The following is a description of a gene set: species: Homo sapiens Any process that activates, maintains or increases the rate of muscle development. Human Gene Set: GOBP_POSITIVE_REGULATION_OF_MUSCLE_ORGAN_DEVELOPMENT, and this is the list of marker genes: ERBB3, MYOD1 (myogenic differentiation 1), MYF6, DLL1, PRKAA1, NACA, CDON, LMOD3, IGF2, CTNNB1, MYF5, MTM1 (NCBI Gene Id 4534), SHOX2, FLOT1, WNT3A, MYOG, MRTFB, BCL2, SHH, CREB1, MEF2C (NCBI Gene Id 4208), ACTN3